Given this list of marker genes GIPC1, FGF5, TGFBR3, FGF8, FGFR1, FGF6, FGF1, FGF2, ANOS1 (NCBI Gene Id 3730), FGF23, FGF4, FGF20, FGF9, FGF17, here is a description of the gene set: Reactome Pathway: FGFR1c ligand binding and activation This pathway depicts the binding of an experimentally-verified range of ligands to FGFR1c. While binding affinities may vary considerably within this set, the ligands listed have been established to bring about receptor activation at their reported physiological concentrations. part of: FGFR1 ligand binding and activation studied in species Homo sapiens